The following is a description of a gene set: Dysregulation of pleiotropic growth factors, receptors and their downstream signaling pathway components represent a central protumorigenic principle in human hepatocarcinogenesis. Especially the Insulin-like Growth Factor/IGF-1 receptor (IGF/IGF-1R), Hepatocyte Growth Factor (HGF/MET), Wingless (Wnt/beta-catenin/FZD), Transforming Growth Factor alpha/Epidermal Growth Factor receptor (TGFalpha/EGFR) and Transforming Growth Factor beta (TGFbeta/TbetaR) pathways contribute to proliferation, antiapoptosis and invasive behavior of tumor cells. This review focuses on the relevant alterations in these pathways identified in human human hepatocellular carcinomas (HCCs). Resultant functional effects are modulated by multiple cross-talks between the different signaling pathways and additional tumor-relevant factors, such as cyclooxygenase-2 and p53. Several specific strategies are currently under development such as receptor kinase inhibitors, neutralizing antibodies and antagonistic proteins, which may improve the systemic treatment of human HCCs. Human Gene Set: BREUHAHN_GROWTH_FACTOR_SIGNALING_IN_LIVER_CANCER Growth factor signaling components up-regulated in hepatocellular carcinoma (HCC). studied in species Homo sapiens from publication Breuhahn K, Longerich T, Schirmacher P (PMID 16799620), and this is the list of marker genes: AXIN2, AXIN1, FZD7, HGF, PIN1, MET, CTNNB1, TGFBR1 (transforming growth factor beta receptor 1), TGFB1, DACT1, TGFBR2, IGF2, TGFA, ERBB2, EGFR